The following is a description of a gene set: studied in species Homo sapiens Spastic/hyperactive bladder Human Gene Set: HP_SPASTIC_HYPERACTIVE_BLADDER, and this is the list of marker genes: GIGYF2, DNAJC13, KIF5A, SNCA, VPS35, LRIG2, LRRK2, EIF4G1, PLP1, GBA1, DARS2